Given this list of marker genes Gprasp1, Ap4m1, Psap (NCBI Gene Id 19156), Ndp, Chmp7, Lamp2, Vcp, Bin1, Mgrn1, Hgs, Slc30a2, Igf2r, Sptbn5, Vps51, Mvb12a, Chmp3, Rufy4, Becn1, Hook1, Prkn, Chmp1b2, Cdx2 (NCBI Gene Id 12591), Clu, Npc1, C9orf72, Sorl1, Vps35, Hspa1a, Plekhf2, Vipas39, Lipa, Rhob, Chmp2a, Laptm5, Kif13a, Lrp1, M6pr, Grn, Mtm1, Aktip, Tmem106b, Rilp, Ubxn6, Chmp6, Slc48a1, Vps54, Pik3r4, Vps39, Rab7b, Ncoa4, Gak, Gnptab, Scyl2, Ankfy1, Epg5, Ccdc91, Stx7, Ap3b1, Snx27, Tgfbrap1, Slc30a4, Dtx3l, Atp13a2, Gga3, Cln3, Vps53, Plekhm2, Sort1, Nedd4, Hspa8, Atg14, Chmp5, Hook2, Vps18, Becn2, Gcc2, Vps41, Pink1, Mfsd1, Vps33a, Vps52, Hook3, Slc30a3, Vps16, Arl8b, Trak2, Fhip1b, Chmp1a, Arf1, Ap3d1, Plekhm1, Vps4a, Vps4b (vacuolar protein sorting 4B), Rab12, Uevld, Als2, Chmp4b, Pcdhga3, Pik3c3, Chmp1b, Lhcgr, Ap1g1, Trak1, Lamp1, Plekhf1, Snapin, Tsg101, Chmp4c, Ehd3, Lyset, Hgsnat, Scarb2, Tpcn2, Rab7, Pcsk9, Rab34, Zfyve16, Snx16, Lyst, Dennd3, Chmp2b, Slc17a9, Vps11, Stx8, Rbsn, here is a description of the gene set: studied in species Mus musculus The directed movement of substances into, out of or within a lysosome. Mouse Gene Set: GOBP_LYSOSOMAL_TRANSPORT